The following is a description of a gene set: Impairment of the complex regulatory network of cell death and survival is frequently the reason for therapy resistance of breast cancer cells and a major cause of tumor progression. We established two independent cell lines from a fast growing mouse breast tumor (WAP-SVT/t transgenic animal). Cells from one line (ME-A cells) are sensitive to apoptotic stimuli such as growth factor depletion or treatment with antitumor agents (e.g. doxorubicin). Cells from the second line (ME-C cells), which carry a missense mutation at the p53 codon 242, are very insensitive to apoptotic stimuli. Co-cultivation experiments revealed that the ME-C cells mediate cell death resistance to the ME-A cells. Microarray and Western blot analysis showed that osteopontin (OPN) is selectively overexpressed by the ME-C cells. This glycoprotein is the most abundant protein secreted by the ME-C cells and we obtained strong indications that OPN is the main antiapoptotic factor. However, the OPN containing ME-C cell medium does not alter the expression level of pro- or antiapoptotic genes or known inhibitors of apoptosis (IAPs). Its signaling involves mitogen-activated protein kinase (MAPK)/extracellular signal-regulated kinase (ERK) kinase (MEK)1/2 as the kinase inhibitor PD98059 restores apoptosis but not the Akt inhibitor. In the ME-A cells, mitochondrial cytochrome c release occurs with and without external apoptotic stimuli. OPN containing ME-C cell medium does not prevent the mitochondrial cytochrome c release and caspase-9 processing. In serum starved ME-A cells, the OPN containing ME-C cell medium prevents caspase-3 activation. However, in doxorubicin-treated cells, although apoptosis is blocked, it does not inhibit caspase-3. This indicates that the ME-A cells distinguish between the initial apoptotic stimuli and that the cells possess a further uncharacterized control element acting downstream from caspase-3. from publication Graessmann M, Berg B, Fuchs B, Klein A, Graessmann A (PMID 17160024) Genes up-regulated in ME-A cells (breast cancer) undergoing apoptosis upon serum starvation (5% to 0% FCS) for 22 hr. Human Gene Set: GRAESSMANN_APOPTOSIS_BY_SERUM_DEPRIVATION_UP studied in species Mus musculus, and this is the list of marker genes: GCA (NCBI Gene Id 25801), DUS3L, PPP1R10, COL4A3, RAD52, COL5A3, PRSS29P, CRB3, CDK5R1, DLC1 (DLC1 Rho GTPase activating protein), TMEM158, GAL3ST1, PPFIBP2, PRELP, NKX2-3, MFSD1, TSPAN33, SFXN2, WASHC2C, RHO, OGN, GRHL2, PTH2, CXCL10, RESF1, REST, EFNB1, HOXB5, SLFN13, PISD, CORO1C, STEAP4, FHIP1B, PRDX4, LOX, PDHB, KCNJ6, POMK, UBA52, SP110 (SP110 nuclear body protein), ETNK1, STAT2, ISG15, APOBEC1, ZFP36L1, CXCL16, IRF2, STRAP (serine/threonine kinase receptor associated protein), GRIN3B, KPNB1, CACNA1A, BST2, KCTD12, CIMIP3, MSL2, CHAC1, CCNC, PES1, VDAC1, IFNGR2, HLA-B, SEMA3B, DDX60, SGK1, ARFRP1, DCAF1, KLHL2, ACTB, TRMT10A, CREM, CLCF1, ABI3BP, SELENOP, CTPS1, BCAN, USP13, PTPN21, GBP4, SAMHD1, ATG10, RPE, GALT, PTHLH, PMEPA1, C4B, CXCR5, ALPL, HMGA2, FOLR1, TM4SF1, LIG3, CCL5, FCGR3A, COL14A1, HEATR6, FES, NNMT, DNMT1, UBA7, ZBP1, PDE1B, N4BP2L1, CCAR2, TLR3 (toll like receptor 3), SPRR1A (small proline rich protein 1A), RNF20, TACR2 (NCBI Gene Id 6865), EGF, GSTM5, TMT1A, TBC1D1, XPR1, CCL15, TMEM140, WDR12, UQCC4, ADCY7, SLC14A2, SOD2, TRAFD1, CYP1A1, JAK3, PTPRT, TIRAP, HSPB1, IRF9, NCK1, POLR3D, TXNIP, PPID, KCNA6, JPH1, SENP1, HELZ2, IL18BP, NOP58, UBXN2B, ALAS1, TPRKB, CASQ2, RBBP9, DST, THEMIS2, TMED5, C8orf82, TRIM8, ADAR, SLC2A3, PLSCR1, PLA2G2E, IFIT3, APMAP, DUSP6, SMYD5, CEBPB, CXCL6, RCAN3 (RCAN family member 3), ARL14EP, VWA5A, HMBS, FGFBP1, DDX25, PRF1, PRDM1, BOC, BCL2L2, EBNA1BP2, CASP7, SLC9A8, EGR1, CYP2B6, HHAT, DTWD1, RECK, WDR75, PTGER4, WFDC21P, BCR, NPVF, UBE2V2, DNAJC3, AP2B1, KNG1, TXNRD3, PIAS1, MNDA, MAX, AQP1, GTF3C6, ZNF746, IFI27, ZNF207, CCN5, KRT5, ZNF670, ERN1 (NCBI Gene Id 63433), NACC2, LMNB1, CLDN3, IRF7, RRP12, VAPA, ZEB2, RNPC3, RHBG, CEP112 (centrosomal protein 112), APEX2, SYNJ2BP, FLCN, LIPA, HSPA14, RCCD1, PARP9, OAS3, BPNT1, SLC39A4, PYHIN1, RCL1, HNRNPA1L2, SHROOM3, PICK1, LY75, SLC22A1, LCE1B, INO80E, XDH, TRUB2, OXA1L, IRGM, FAM118B, SKIC8, CSF1, UTP11, ASIP, NDUFAF4, SLC23A1, TCEAL1, GPAA1, MTFP1, ANGPT1, CMPK2 (NCBI Gene Id 129607), DFFB, ADCY3, MEST, ELK1, IFIT1B, MYOC, RTP4, PRSS23, ADI1, ATF4, TEAD4, PHLDB2, AEN, DCUN1D1, PFDN5, TOR3A, MCCC2, HOXB8, CIP2A, WDR4, HADH, ITSN1, FAM210B, PARP3, CEBPG, FSTL1, GDF3, KDF1, NECAB2, PCDHB18P, HNRNPAB, NMNAT1 (NCBI Gene Id 64802), TAC4, CCSER2, IVNS1ABP, MRPL57, SOX4, CCT4, REV1, PIPOX, PLEC, TMEM258, SLC10A6, IKBKB, RTL6, TBCA, IFIH1, CNTNAP4, WNT7B, TRIM21, HOXB9, GADD45A, CEBPD, APOL1, MESP1, ETFRF1, USP18, TRIP4, TASOR2, TPBG, SPRY1, BCL6, KCNMB2, GADD45B, EXOSC1, CDON, CCN2, TRIM34, DBH, YPEL1, DIMT1, OASL2P, DAPK2, CCL7, PARP12, RIN2, SLC35E4, DYNC1LI1, CYP4F8, TXNDC16, FJX1, C3, URI1, SHMT1, BCL9, ARMC7, LTBP2, HSPA8, NCL, FAS, HTATSF1, SPHK2, CDK5, IRS1, STK11IP, PHIP, RND3, PNPT1 (polyribonucleotide nucleotidyltransferase 1), MEPCE, SLC25A44, GGTA1, ACOT6, LGALS3BP, USP25, TBXA2R, PDE7A, RFXANK, YIPF4, CP, BECN1, LAMP3, ABCC8, CAPN6, AFG2A, PCDHB15, UROC1, KIFC2, GALC, EFNB2, LMO4, ING3, BGN, ACTL7B, MED28, RSAD2, FBN1 (fibrillin 1), RETREG3, OSMR, CXCL2, ENC1, ZNF672, IRF1, TIFA, TMPO, COL9A1, MMD, PTPN14, GRHL1, TAF1D, ERLIN1, SLC29A2, TLR2, FSIP1, BEAN1, AATF, NXNL2, IFI35, HIPK2, RIOK2, TAP2, EHD2, KALRN, LRIG1, ARHGAP39, CDCA3, CDHR4 (NCBI Gene Id 389118), PNP, UBE2I, DKK3, OASL, SERF1A, TMEM268, NEDD9, IFIT2 (NCBI Gene Id 8375), HSD11B1, ELOVL4, NEUROG3, IL1R1, OSGIN2, IFNAR2, OAS1, STAM2 (signal transducing adaptor molecule 2), VILL, WDR77, AICDA, TOR1AIP1, IHH, NIFK, MYC, ELP4, TRIM25, SLC6A9, OTOF, CFB, PATZ1, PDK4, TRAM2, LZTFL1, CMTM6, DPF3, PI4K2A, PIK3C3, CNIH2, CLEC2D, SAA1, PSMB10, PCGF2, SOCS1, SMR3B, PLK2, DNM3, RPL30, CLIP1, SEPTIN6, RPL35, SURF6, ERAP1, PCDHB16, ZNF91, RBMX, CCL2, TUBB4B, PPIF, REV3L, TP53INP1, IAPP, RRP15, IGFBP7, FNDC3A, NMD3, FBXW2, HMGCR, PRRX1, MMP3, RAD1, ABCC5, HOXB7, PLPP3, H3C13, ALG13, NDUFB2, POU3F4, OSR1, MOCS1, LIFR, SURF4, PLAGL1, LRG1, SLC9B1, MYD88, CASD1, CNTFR, INTS8, DCC, INHBB, ZNF503, GBP6, HSD11B2, OAS2, DAXX, MIGA2, RABL3, CCNH, CCN3, ST3GAL4, COL3A1, CLPS, CRHR1, MARCHF5, GFRA2, FAM216A, CD59, LRRC3B, ETF1, CYP21A2 (cytochrome P450 family 21 subfamily A member 2), CD2, TCIM, TRIB2 (NCBI Gene Id 28951), SIRT4, HEATR1, RUNX1, CHCHD5 (NCBI Gene Id 84269), HNF4A, TMEM168, ERMAP, CUL4A, EFNB3, PLP2, AHR (NCBI Gene Id 196), TMEM167A, DNAJC27, RNF32, GBP2, COL5A2, SEPTIN7, QTRT2, DBT, ADAMTS10, DMP1, PHLDA2, PCDHGB1, RPS18, SLC24A3, PLEKHF2, ELN, STAT1, PDGFRB, ARAP2, ATL3, SP100, ZBTB32 (NCBI Gene Id 27033), TP53, RBM43, TAF1A, PIP5K1B, INTS7, IGHG1, PARP14, SLC18A1, ASZ1, IGFBP4, IFI44, DONSON, TYW1, LGALS12, EIF2AK2, AVPR1A, SYCP3, MX1 (MX dynamin like GTPase 1), GHR, SPTLC1, YIPF5, TRIM5, SNRNP48, RIMS2, SLFN12, RNF144B